Given this list of marker genes DCAF16, JAKMIP2, PTPRE, TRIM38, TNPO2, KLHL20, SLC2A5, FBXO30, KANK2, CACUL1, CD79B, UTRN, CD47, NUDT12, UTP11, PCDH9, BAIAP2L1, AFM, C1QA, SLC43A1, RGS11, FAM184B, H3C10, KNL1, KMO (kynurenine 3-monooxygenase), RBBP9, ZNF232, PCAT18, MAGED1, SIAH1, ARHGAP32 (NCBI Gene Id 9743), MXI1, CYTH3, AFF1, H2BC12L, RPP30, DPYD, MRAS, RING1, RUBCNL, UXS1, GRHPR, PSME2, GALNT3, DKC1, CTCF (NCBI Gene Id 10664), ALG10B (NCBI Gene Id 493903), TAF4, PSME4, CALR, CRYM, GNG8, SKIDA1, WT1, PGM3, FEN1, TSPAN15, C3orf52, FCRL1, H2BC7, KASH5, HIP1, AGPAT4, LCNL1, WRNIP1, CLGN, SPRY2, HOXB2, CLEC2D, SSBP2, DACT1, BIRC2, H2AC6, CTBP2, IQGAP2, ATP6V1C2, MC3R, GABRB1, NPTX1, RAPGEF5, SRSF8, ZNF512, SBF2, NREP, TUBB6, CYP2R1, CD8B, ORMDL3, KLB, ZNF618, ADM, TMEM263, UBE2E1, CLDN12, CLEC2B, ANKRD10, NPC2, TTYH2, NUBP1, ACSM3, ZNF285, ADPRM, LATS2, ZEB1, STX7, CMTM7, CMTM3, CYB5A, ZNF815P, CORO1C, KCNQ5, DTHD1, NME8, HDHD2, MFAP1, LINC00115, ALG2, ABCB4, ZCCHC7, FAM110D, FBXO42, HNRNPA2B1, UPF3B, FBXO15, TNFRSF18, RASAL2, NEGR1, ZNF260, IGLJ3, TCL1A, CPD, IGKV1D-13, MTMR1, GULP1, AAK1, TOP1, AMN1, LINC02483, UBE2H, CLCA2, GPATCH2L, LINC00587 (NCBI Gene Id 414319), ATXN3L, BCAR4, FAM30A, RMND5A, GUCY1A1, SFMBT2, PSMB4, RAB30, ADARB1, SGPL1 (NCBI Gene Id 8879), MORC2-AS1, IRS2, FOXP1-IT1, SLC39A7, GNB4, RAE1, TMEM176A, UNKL, H2AC15, STMN1, ADAMTS3, RGS5, PIK3CG, PDGFC, ARHGEF26-AS1, MAPK14, CERS6, PELI2, GPALPP1, ZNF354A, STK26, IL5, SLC1A4, STAM, RAI2, ZNF134, SLC2A4 (NCBI Gene Id 6517), CRNDE, SLC38A9 (NCBI Gene Id 153129), OR51B2, DZIP3, ZNF28, KLHDC8A, here is a description of the gene set: Tumor growth is associated with a profound alteration of myelopoiesis, leading to recruitment of immunosuppressive cells known as myeloid-derived suppressor cells (MDSCs). Analyzing the cytokines affecting myelo-monocytic differentiation produced by various experimental tumors, we found that GM-CSF, G-CSF, and IL-6 allowed a rapid generation of MDSCs from precursors present in mouse and human bone marrow (BM). BM-MDSCs induced by GM-CSF+IL-6 possessed the highest tolerogenic activity, as revealed by the ability to impair the priming of IFN- -producing CD8+ T cells upon in vivo adoptive transfer. Moreover, adoptive transfer of syngeneic, GM-CSF+IL-6-conditioned MDSCs to diabetic mice transplanted with allogeneic pancreatic islets resulted in long term acceptance of the allograft and correction of the diabetic status. Cytokines inducing MDSCs acted on a common molecular pathway. Immunoregulatory activity of both tumor-induced and BM-derived MDSCs was entirely dependent on C/EBP transcription factor, a key component of the emergency myelopoiesis triggered by stress and inflammation. Adoptive transfer of tumor antigen-specific CD8+ T lymphocytes resulted in therapy of established tumors only in mice lacking C/EBP in myeloid compartment. These data unveil another link between inflammation and cancer and identify a novel molecular target to control tumor-induced immune suppression. We used gene expression analysis to identify those factors, secreted by tumor-infiltrating MDSC, which could drive emathopoiesis. Moreover we compare gene expression profile of tumor-induced MDSC, obtained from either the spleen and the tumor infiltrate of tumor bearing mice, and in vitro bone marrow-derived MDSC. from publication Marigo I, Bosio E, Solito S, Mesa C, Fernandez A, Dolcetti L, Ugel S, Sonda N, Bicciato S, Falisi E, Calabrese F, Basso G, Zanovello P, Cozzi E, Mandruzzato S, Bronte V (PMID 20605485) species: Homo sapiens Genes down-regulated in CD11b BoneMarrow from BALBc mouse versus CD11b BoneMarrow from BALBc mouse incubated with GMCSF and IL-6. Human Gene Set: GSE21927_UNTREATED_VS_GMCSF_IL6_TREATED_BONE_MARROW_DN